The following is a description of a gene set: Human Gene Set: WP_SULFATASE_AND_AROMATASE_PATHWAY studied in species Homo sapiens Sulfatase and aromatase pathway, and this is the list of marker genes: SLCO4C1, SLCO4A1, SULT1E1, HSD17B3, SLCO1A2, HSD17B1, SLCO1B3, ESR1, SLCO2B1, HSD17B2, HSD3B1, ESR2, CYP19A1, SLCO1B1